Given this list of marker genes EPS8L3, GJB2, PPP2R3C, APOE, AR, ZBTB20, ITGB4, GJB6, CYP17A1, HR, SNRPE, LSS, TBX3 (T-box transcription factor 3), here is a description of the gene set: Absent axillary hair Human Gene Set: HP_ABSENT_AXILLARY_HAIR Absence of axillary hair. studied in species Homo sapiens